The following is a description of a gene set: Difficulty standing studied in species Homo sapiens Human Gene Set: HP_DIFFICULTY_STANDING, and this is the list of marker genes: CYP27B1, FAR1, ATP2B3, ITPR1, SLC34A3, TBCE, KY, DYSF, TRMT5, DYM, TK2, CLN8, ABCC8, VDR (vitamin D receptor), LRP12, GRIN2A, TFG, SMS, GPAA1, CYP2R1, MYOT, WARS2, GRM1